Given this list of marker genes Rxra, Ncoa1, Prcp, Ncor1, Thrb, Med1, Thra, Gphb5, here is a description of the gene set: A nuclear receptor-mediated signaling pathway initiated by a thyroid hormone binding to an intracellular receptor of the nuclear receptor protein family, and ending with regulation of a downstream cellular process, e.g. transcription. species: Mus musculus Mouse Gene Set: GOBP_THYROID_HORMONE_RECEPTOR_SIGNALING_PATHWAY